Given this list of marker genes ANXA3, TULP4, AMDHD1, PERP, GABRP, MYBPC1, CA2, THRB, N4BP2L1, PDK4, AZGP1, PIP, CHPT1, WLS, SERPINA1, ZBTB16 (NCBI Gene Id 8070), LINC00472, TRIM2, TOM1L1, CYP4X1, KCTD18, CNN1, SGK3, BORCS7, LAMB3 (laminin subunit beta 3), TRIM29, HSDL2, SYNM, PPP4R4 (NCBI Gene Id 57718), KRT5, ITGA2, MGST1, GPM6B, PIGR, PTK2, SFRP1, KRT15, DERA, EHF, FBXO3, CDH1, FAM3B, CYP2J2, PI15, CGNL1, ISM1, CCPG1, ESD, KRT14, TM4SF18, MYH11, LYPD6, MEX3C, CPB1, CYB5R2, SORL1, KRT17, CNOT7, RAB1A, CRYZ, KBTBD7, EGFR, DMD, CD36, NTRK2 (neurotrophic receptor tyrosine kinase 2), STC2, FHOD3, RYR3, ID4, ELF5, WIF1, FAM76B, APLP2, PPP6C, CHL1, IL20RA, IL17RB, MYLK (myosin light chain kinase), PAPOLA, FMO5, VPS35, PGR, ADAMTS5, MPPED2, BHLHE41, LAMP2, PAWR, HAUS1, ACTA2, DST, OXTR, CLIC6, GRIA2, SMAD2, PDZK1 (NCBI Gene Id 96133), MUC6, here is a description of the gene set: Human Gene Set: TURASHVILI_BREAST_LOBULAR_CARCINOMA_VS_LOBULAR_NORMAL_UP studied in species Homo sapiens BACKGROUND: Invasive ductal and lobular carcinomas (IDC and ILC) are the most common histological types of breast cancer. Clinical follow-up data and metastatic patterns suggest that the development and progression of these tumors are different. The aim of our study was to identify gene expression profiles of IDC and ILC in relation to normal breast epithelial cells. METHODS: We examined 30 samples (normal ductal and lobular cells from 10 patients, IDC cells from 5 patients, ILC cells from 5 patients) microdissected from cryosections of ten mastectomy specimens from postmenopausal patients. Fifty nanograms of total RNA were amplified and labeled by PCR and in vitro transcription. Samples were analysed upon Affymetrix U133 Plus 2.0 Arrays. The expression of seven differentially expressed genes (CDH1, EMP1, DDR1, DVL1, KRT5, KRT6, KRT17) was verified by immunohistochemistry on tissue microarrays. Expression of ASPN mRNA was validated by in situ hybridization on frozen sections, and CTHRC1, ASPN and COL3A1 were tested by PCR. RESULTS: Using GCOS pairwise comparison algorithm and rank products we have identified 84 named genes common to ILC versus normal cell types, 74 named genes common to IDC versus normal cell types, 78 named genes differentially expressed between normal ductal and lobular cells, and 28 named genes between IDC and ILC. Genes distinguishing between IDC and ILC are involved in epithelial-mesenchymal transition, TGF-beta and Wnt signaling. These changes were present in both tumor types but appeared to be more prominent in ILC. Immunohistochemistry for several novel markers (EMP1, DVL1, DDR1) distinguished large sets of IDC from ILC. CONCLUSION: IDC and ILC can be differentiated both at the gene and protein levels. In this study we report two candidate genes, asporin (ASPN) and collagen triple helix repeat containing 1 (CTHRC1) which might be significant in breast carcinogenesis. Besides E-cadherin, the proteins validated on tissue microarrays (EMP1, DVL1, DDR1) may represent novel immunohistochemical markers helpful in distinguishing between IDC and ILC. Further studies with larger sets of patients are needed to verify the gene expression profiles of various histological types of breast cancer in order to determine molecular subclassifications, prognosis and the optimum treatment strategies. Genes up-regulated in lobular carcinoma vs normal lobular breast cells. from publication Turashvili G, Bouchal J, Baumforth K, Wei W, Dziechciarkova M, Ehrmann J, Klein J, Fridman E, Skarda J, Srovnal J, Hajduch M, Murray P, Kolar Z (PMID 17389037)